The following is a description of a gene set: Abnormality of Descemet's membrane, which is the basement membrane of the corneal endothelium. Human Gene Set: HP_ABNORMAL_DESCEMET_MEMBRANE_MORPHOLOGY species: Homo sapiens Abnormal Descemet membrane morphology, and this is the list of marker genes: FOXE3, CYP1B1, PAX6, TEK, COL8A2, KCNJ13, GRHL2, FOXC1, ZEB1, LTBP2, AGBL1, MYOC, PITX2, SLC4A11, OVOL2, VSX1, TCF4